Given this list of marker genes Chd4, Dtnbp1, Lin37, Cnp, Apex1 (NCBI Gene Id 11792), Ly6g6c, Eci1, Khk, Cyb5a, Calm4, Aarsd1, Cfdp1, Pfdn2, Cotl1, Ak2 (adenylate kinase 2), Dexi, C1qtnf12, Pgls, Atp5mc1, Cd2, Manf, Magoh, Sprr1a, Psmb3, Mbp, Tubb5 (NCBI Gene Id 319597), Cnih4 (cornichon family AMPA receptor auxiliary protein 4), Mrps18b, Pin1, Atp5if1, Rpl3, Tceal9, Tceal8, Nfic (nuclear factor I/C), Evpl, Aimp2, Kdelr1, Uqcrh, Slpi, Clca2, Mafg, Tpgs1, Mvb12a, Chchd10, Stx4a, Timm17b, Ndufa8, Arl6ip4, Vps28, Iscu, Wnt4, Mrps36, Rpl9, Mrpl41, Gemin7, Eif3i, Rps3a1, Sparc, Aknad1, Gstm1, Ncbp2as2, Cbr3, Ten1, Arl4a, Ier3, Rcsd1, Use1 (unconventional SNARE in the ER 1 homolog (S. cerevisiae)), Antkmt, Atp5f1c, Mrpl55, Psenen, Rpl5, Mdh1, Mrps24, Emc10, Rpl10, Macrod1, Zfp503, BC064078, Gid8, Cavin3, Clic3, Mrpl12, 1700025G04Rik, Pdrg1, Rras (NCBI Gene Id 20130), Tmed3, Ebp, Hcfc1r1, Polr1g, Gimap1, Triap1, Npc2, Aprt, Klf4, Vti1b, Rgs10, Atp6v1f, 0610010K14Rik, Mrps18a (mitochondrial ribosomal protein S18A), Gnb1, Mrpl33, Rac3, Napsa, Gng10, Sri, Grcc10, Pmf1, Psph, Sftpa1, Senp6 (NCBI Gene Id 74825), Slc25a3, Phb2, Mgst3, Rpl6, Cuta, Tmem250 (transmembrane protein 250), Ube2m, Ubb-ps, Cirbp, Trappc3, Rarres1, Rplp0, Krtcap2, Reep5, Abracl, Phax, Zcchc17, Snrpd2, Tmsb10, Arl3, Gtf3c6, Tnfrsf4, Ppib, Pebp1, Rpl18, Vsir, Ndufa13, Pmm1, Adrm1, U2af1, Ssna1, Cmtm8, Exosc6, Pycard, Hint1, Taf9, Ybx1, Rexo2, Rpl13a, Dtymk, Atp5mc2 (ATP synthase membrane subunit c locus 2), Smim12, Fam162a, Ubxn4, Grb2, Bod1, Psmb6, Hbegf, H2aj, Tmem9, Hsd17b10, Mxd4, Pdzk1ip1, Ormdl2, Ndufb9, Rabac1, Polr2g, Ly86, Anapc11, Malat1, H2-Ab1, Ggct, Nbdy, Stk19, Gc, Kxd1, Lgals3, Gstm5, Rab5if (RAB5 interacting factor), Psma3, Srsf9, Sec11c, Hras, Rps27a, Nop16, Krt1, Avpi1, Sdc4, Il34, Gm94, S100a14, Rpl28, Snrpd1, Snw1, 1810037I17Rik, Naxd, Trappc6b, Uqcc2, Serf2, Nt5c3b, Krt7, Siva1, Tecr, Tmem219, Sf3b4, Selenoh, Lgi2, Ube2k, Ppig, Aimp1, Naxe, Cfl1, Klk8, Map2k2, Ndufs6, Ap1s1, Acta2, Spr, Cox5a, Eif4e2, Mrps16, Prxl2b, Ranbp1 (RAN binding protein 1), Mrpl40, Smco4, Ppp4c, Cenpx, Lmo4, Kplce, Rps14, Zfand2b, Ift27, Alad, Dctpp1, Rgs4, Rps15a-ps6, Lypd3, Rbm42, Cox14, Trnau1ap, Acbd4, Efna1, Mgst1, Taf10, Syngr2, Stmp1, Mpc1, Tmem242, Tbcb, Ptms, Txn2, Ece1, Ppp1r13l, Cope, Thap3, Mrpl27, Gstp1, Sub1, Smdt1, Bex3, Hsbp1, Mrpl14, Gadd45gip1, Emc8, Pla2g12a, Ndufv3, Trappc6a, Foxn3, Mrpl53, Rpl12, 2510002D24Rik, Depp1, Eif3k, Ppp1r14b, Mcrip1, Denr, Calm2, Fam89b, Chmp2a, Svbp, Rps16, Zfpl1, Pomp, Mrpl48, Timm13, Etfb, Eif4g1, Trmt112, Arpp19 (NCBI Gene Id 72570), Park7, Capzb, Plac8, Bbln, Nsd3, Jund, Notch1 (notch 1), Mrps34, Psma2, Emc4 (NCBI Gene Id 68032), Rps7, Commd1, Naa10, Mpst, Gpha2, Hoxa7, Rps8, 2310033P09Rik (RIKEN cDNA 2310033P09 gene), Dnajc19, Rpl35, Dcn, Tmem40, Rps4x, Cela1, Tmbim4, Erh, Rack1, Phlda3 (pleckstrin homology like domain, family A, member 3), Rab25, Fdx1, Pfdn1 (prefoldin 1), Slc6a8, Zcrb1, Ifi35, Cic, Rplp2, Ier3ip1, Lgals7, Ptma, Atox1, Tmem50a, Rps11, Nt5c, Psmd7, Fis1, Mrpl54, Wasf2, Calm1, Yif1a, Tex264, Tmem45a, Bsg, Zfp703, Cdc123, H2-Eb1, Acot8, Trappc1, Dynll2, Iffo2, Stub1, Hilpda, Crip2, Psmg3, Klf2, Ypel3, Ptgds, Cltb, Ndufb10, Nhp2, Rps27l, Pop5, Trappc2l, Ifi30, Wdr18, Hint2, Samd4b, Pkig (protein kinase inhibitor, gamma), Rpl19, Cdk2ap2, Pcbp2, Aurkaip1, Mycbp2, Atg101, H2-DMa, Rnaseh2c, Mrps15, Pgp, Polr2i (polymerase (RNA) II (DNA directed) polypeptide I), Psmc3, Rab24, Ssu72, Rplp1, Bri3, Rps19, Josd2, Gatd3a, Ubald1 (UBA-like domain containing 1), Akr1c13, Cdc42ep3, Mgll, Phf23, Sdhc, Eif4ebp1, Mrpl30, Cldn3, Cdc42ep5, Psmb10, Psme2, Anp32a, Anp32b, Rfxap, Atp6v0e, Serbp1, Mpc2, Grap, Dmac1, Cd63, Rpl32, Bcl2l12, Metrnl, Pgrmc2, Arf5, Pcbd2 (NCBI Gene Id 72562), Ltb, Tomm5, Gatad1, Tmsb4x, Nudt16l1, Tmem160, Capns2, Faap20, Cd9, Gm9320, Myl9, S100a16, Cd79b, Mrps14, AW112010, Rpl21, Inmt, Dbi, Rpl31, Mettl5, Smim30, Tmem54, Dynlrb1, Ethe1, Tmed10, H1f0, Rab4b, Ftl1, Klf13, Srrm2, Dgcr6, Polr1d, Hmgn1, Hagh, Ly6d, Rtraf, Higd2a, Mrpl13, Usf2, Myl6, Cfap298, Mrpl32, Eif1ax, Apoc1, Tubb4b, Fxyd3, Fxyd5, Psma7, Cib2, Cst3, Cela2a, Hmgb2, Trir, Nenf, Dnajc30, Hacd2, Jtb, Nme1, Smim29, Pafah1b3 (NCBI Gene Id 18476), Emc7, Arpc1b, Smagp, Cib1, Ndufv2, Pop7, Tomm6, Otub1, Gar1, Atp5mf, Gga1, Elof1, Bmyc, Ubxn1 (NCBI Gene Id 98173), Prdx5, Ddr1, Tma7, Cxcl14 (NCBI Gene Id 80491), Atp5po, Fam25a, Nudt18, Atp6v1g1, Ubb (ubiquitin B), Dctn3, Cisd1, Grpel1, Ifitm3, Eef1d, Zmat5, Ralbp1, Rpl11, Uqcc3, Atp6v0b, Pabir1, Selenow, Snapc5, Ndufa12, Wdr83os, Dynll1, Pdlim2, Atf4, Acbd6, Rp9, Pdcd5, Ino80b, Ccl2, Mif (NCBI Gene Id 17319), Apoe, Sh3bgrl3 (NCBI Gene Id 73723), Sfr1, Mmp24os1, Card19, Ubl7, Wfdc2, Fam241b, Retnlg, Prr13, Rnf126, Ldhb, Syf2, Rpsa, Ndufs8, Glrx5, Rpl31-ps12 (ribosomal protein L31, pseudogene 1 2), Lamtor1, Krt17, Emp2 (epithelial membrane protein 2), Chrac1, Nudt14, Rex1bd, Rhoh, Ccdc107, Chmp4b, Mcee, Tsn, Vcf1, Nfkbib, Rnasek, Nr2c2ap, Blvrb, Sf3b2, Nudt3, Fcgbp, Psmb2, Tmem14c, Ebna1bp2, Sod2, Rps20, Ccl27a, Ppdpf, Pnrc1, Pou3f1 (NCBI Gene Id 18991), Pdgfa, Csnk2b, Itm2b, Rpl24, Coq7, Clasrp, Mrpl58, Nans, Gsto1, Ift43, Gipc1, H2-Aa, Eif3g, H2az2, S100a11, Mrpl36, Scamp3, Orai1, Fgfbp1, Fdps, Thap7, Ctsz, Ccs, Psma4, Yy1 (YY1 transcription factor), Dpysl2, Rps3, Dnajc4, Nedd8, Sertad1, Tmem134, 2310039H08Rik, Ube2s, BC031181, Tex261, Rps5, Psmb8, Rala, Mrpl34, Nfkbia (NCBI Gene Id 18035), H2-K1, Tmem45b, Lxn, Eif1, Rarg, Ctsh, Coa3, Pdap1, Arpc5l, Znhit1, D8Ertd738e, Atp5pf, Ino80e, Psmb1, Exosc8, Mien1, AI467606, Mrpl17, Scand1, Kdm6b (KDM1 lysine (K)-specific demethylase 6B), Lat, Plpp3, Uqcr10, Bax, Ssbp3, Tnfrsf18, Rps9, Gtf2h5 (general transcription factor IIH, polypeptide 5), Mrpl4, Sf3b5, Ccnd2, Ift20, Dusp22 (NCBI Gene Id 68676), Gtf2a2, Commd4, Ppp1r35, Fxr2, Smarcb1, Ssbp4, Cnpy2, Igfbp7, 1110065P20Rik, Smim14, Exosc4, Scnm1, Sac3d1, B2m, Tmem208, Emd, Set, Ier2, Med10, Faim, Rpp25l, Ifi27, Mpv17l2, Nsfl1c, Ostc, Pfdn6, Snrpc, Ndufc1, Lamtor5 (late endosomal/lysosomal adaptor, MAPK and MTOR activator 5), Nectin1, Tuba4a, Bad, Stx8, Npm1, Akr1a1, Ndufab1, Hmg20b, Fermt1, Spint2, Vgll4, Pttg1, Atp5mc3, Bloc1s1, Mpdu1, Rps27, Oas1f, Cox8a, Ube2c, Mea1, Grhpr, Smim20, Gpx1 (NCBI Gene Id 14775), Ccdc124, Manbal, Rpl36, Higd1a, Dazap1, Dmkn, Pold4, Rpl22, Dpm1, Plet1, Fth1, Ssr4, Tpt1, Banf1, Psmb9, Mospd3, Tmem11, Tm2d2, Arhgdia, Npm3, Ddrgk1, Wbp2, Uqcc4, Tm4sf1, Casz1, Mt4, Fkbp3, Vps72, Sftpc, Krt10, Tnni3, Prelid1, Wdr74, Lage3, Mbd3 (methyl-CpG binding domain protein 3), Mrpl51, Nabp2 (nucleic acid binding protein 2), Cebpa, Psmb4, Vps29, Anp32e, Eef1b2, Ccl5, Lrp4, Sfn, Nbl1, Ncf4, Urah, Echdc2, Sostdc1, Zfp750, Mrpl57 (NCBI Gene Id 67840), Cryab, Psme1, Exosc7, Scp2, Lck, Uqcr11, Zfp414, Rpl41, Tcf7l2, Rtf1, Ndufb11, Znrd2, Dbndd2, Apoc3, Tm2d3, Tmem176b, Hypk, Rpl8, Exosc5, Frg1, Lsm4, Micos10, Pnkd, Pnn, Rbm25, Atp5f1d, Cdkn1a, Fahd1, Bag1, Rbfa (ribosome binding factor A), Vamp8, Tmem147, Prrg2, Arpc3, Swi5, Ndufa11, Cdc37, Endog, Ifitm2, Dhrs4 (NCBI Gene Id 28200), Ech1, Dnajc2, Pfn1, Mrpl24, Atp5pd, Mrpl42, Cebpzos, Bcl9l, Gpatch4, Tmem238, Bgn, Akt1s1, Med8, Psma6, Plekhj1, Dnajc13, Fabp5, Abhd17a, Pfdn5, Ninj1, Dusp2, Rps24, Lamtor2, Mrpl2, Babam1, Ndufb5, Sys1, Oaz1, Btf3, Fkbp2 (FK506 binding protein 2), Hsd17b8, Cd74, Il11ra1, Erp29, Calm5, Snrnp70, Atp5mg, Ndufa4l2, Clpp, Arl2, Bcl7c, Dpy30, Bag6, Parl, Guk1, Cstb (NCBI Gene Id 13014), Rps13, Ctnnbip1, 2610528J11Rik, Aplp1, Cst6, S100a13, Ndufaf8, Tle5, Spag7, Cdkn2d (NCBI Gene Id 12581), Drap1, Lamtor4, Psmd4, Rpl13, Vkorc1, Glrx2, Fcgr2b, 2310011J03Rik, Ctdnep1, Mrpl43, Mtarc2, Nrarp, Tmem192, Abhd11 (NCBI Gene Id 68758), Sec61b, Nrtn, Rpl17, Ndufs3, Sult5a1, Snrpd3, Coro1a, Dnlz, Mrpl23, Gnptg, Sin3b, Klf5, Pabpn1, Lrrc8a, Rbm26, Mrps26, Ly6e, Map1lc3a (NCBI Gene Id 68411), Hpf1, Uchl3, Szrd1, Naca, Dapl1, Tmem234, Rps18, Vasp, Selenos, Tspo, Dad1, Micos13, Itgb1bp1, Fbl, Ndufs7, Atraid, Naa38 (N(alpha)-acetyltransferase 38, NatC auxiliary subunit), Ndufa7, Elob, Cox7a2l, Cops5, Akip1, Mrpl28, Lmo1, Tmem205, Ndufb8, Rpl22l1, Nfix, Clic4, Spcs1, Edf1, Srp14, Hyi, Rpl7a, Clic1, Ap2s1, Commd7, Ndufb7, Ing2, Rrp1, Lsm2, Nop10, Nme2, Stmn1, Snrpa (NCBI Gene Id 53607), Phpt1, Sdhb, Med28, Mocs2, Sbsn, Fam110a, Kcnk7, Srrm1, Hebp2, Ndufa6, Id3, Selenok, Cbr1, Hspe1, Cox4i1, Mrps12, Nradd, Rbm8a, Ppp1r11, Ndufb6, Rpl18a, Mpnd, Sra1, Commd9, Brk1, Rpl27a, Nupr1, Krtdap, Tmed9, Eif3f, Ccdc12, Gpx4, Ptpn1, Rps10, Tssc4, Gnb2, Nxt1, Sarnp, Myl12a, Klc3, Psmb5, Arhgdib, Polr2e, Ndufc2, Mplkip, Ostf1, Eif5a, Gata3, Hs3st6, Rpl14, here is a description of the gene set: Mouse Gene Set: TABULA_MURIS_SENIS_SKIN_BASAL_CELL_OF_EPIDERMIS_AGEING species: Mus musculus from publication Tabula Muris Consortium (PMID 32669714)